The following is a description of a gene set: Any process that decreases the frequency, rate or extent of cell communication. Cell communication is the process that mediates interactions between a cell and its surroundings. Encompasses interactions such as signaling or attachment between one cell and another cell, between a cell and an extracellular matrix, or between a cell and any other aspect of its environment. Mouse Gene Set: GOBP_NEGATIVE_REGULATION_OF_CELL_COMMUNICATION species: Mus musculus, and this is the list of marker genes: Kalrn, Bcl2l10, Foxh1, Cgas, Cul3, Actn3, Oprk1, Slc24a1, Sharpin, Nxn, Pde4c, Icam1, Ddrgk1, Ppif, Dyrk2, Eid2, Cer1, Sorcs2, Tle4, Nherf4, Wdr91, Rgs20, Ddit4l, Leprotl1, Fgf10, Itga3, Ptgs2os (prostaglandin-endoperoxide synthase 2, opposite strand), Sbno1, Nkiras1, Cav3, Epha7, Ffar3, Prex1, Fkbp1a, Traip, Cd300lf, Zdhhc18, Wnt1, Sco1, Ctnna1, Neurod1, Dgkd, Pycr1, Bdnf, Ddias, Tnfaip1, Men1, Edn3, Mgrn1, Tnfrsf4, Trex1, Npy2r, Fam89b, Hmgcr, Tgif1, Htr2a, Cav1, Dkk3, Rgs1, Arc, Dusp1, Endog, Arrdc1 (arrestin domain containing 1), Snai1, Trim67, Nme5, Ar, Padi2, Trabd2b, Ager, Inpp5a, Gstp3, Fgfrl1, Ppp2ca, Dnaja1, Cry1, Mapkap1, Ppt1, Dhx58, Hapstr1, Insig1, Pde8b, Syt4, Grk5, Gjd3, Prkcq, Tnip1, Dusp10, Mark3, Lyplal1, Gper1, Nprl3, Atm, Zfp592, Tle7, Sulf1, Socs5, Stambp, Csnk2a1, Fktn, Aida, Lect2, Rgs2, Nkd2 (NCBI Gene Id 72293), Acod1, Gpr21, Prkar2a, Nprl2, Eif2a, Bcl2l12, Cyp2j6, Lingo1, Kcnj6, Styxl2, Rnf152, Ttll12, Tbk1, Epm2a, Xdh, Tnip2, Sh3bp1, Gnal, Kank2, Pde3a, Snx1, Bmp4, Cd109, Fgf9, Frzb (frizzled-related protein), Arhgap12, Prkar2b, Lmo3, Crh, Tnf, Igbp1, Htr1b, Spi1, Gfral, Hmox1, Sike1, Adora1, Zfp385a, Sfrp5, Rnf31, Bmper (NCBI Gene Id 73230), Cdc34 (cell division cycle 34), Wnt5b, Rnf113a1, Atxn1, Cyrib, Rnf126, Tyro3, Ncor1, Aars1, Glis2, Faim2, Plin5, Lemd2, Igfbp5, Sec14l1, Fbxw8, Spart, Ppia, Opa1, Stau2, Skor1, Hhex, Dusp7, Apln, Il10 (NCBI Gene Id 16153), Ffar4, Mapt, Tmem53, Ezh2, Hgs, Itga1, Tnfrsf23, Rgs19, Ubac2, Kcnc4 (potassium voltage gated channel, Shaw-related subfamily, member 4), Srf, Pea15a, Nr4a2, Tax1bp1, Calr, Ska3, Tmem170b, Dusp2, Adar, Ifi203, Ly6g6e, Snx6, Otud5, Prdm16, Itpr1, Ptger3, Alg13, Gmip, Faiml, Spink1, Emd, Itfg2, Oas1e, Pafah1b1, Dll1, Il7, Ankrd6, Prdm14, Isl1, Nbl1, Xbp1, Stat3, Homer2, Sh2d1a, Ppp6c, Ptpmt1, Tgfb2, Lamp2, Fermt1, Hgf, Fgg, Rb1cc1, Arhgap17, Txndc12, Mmp12, Smpdl3b, Dcn, Peli1, Strip1, Slc2a10, Rps6kb2, Necab2, Lilrb4b, Arhgap29, Herc2, C1ql4, Fbxl2, Mstn, Pten, Bok, Rubcn, Grk3, Mup11, Fzd6, Cx3cr1, Pirb, Trp53, Parp14, Cd300a, Dusp13b, Lats1, Dyrk3, Gja1, Nrarp, Chrna10, Lztr1, Nherf2, Pde10a, Hey2, Pbld2, Olfm4, Dsg3, Pibf1, Edn1, Crebrf, Tcf21, Tgfbr3, Pdpk1, Nos1, Wnk1, Hacd3, Notum, Lefty1, Pawr, Tmc8, Tsc1, Pik3ip1, Sdhaf2, Atf3, Aspn, Megf8, Dmd, Dag1, Trim32, Cyp7b1, Hmgb2, Shisa2, Dusp5, Cd74, Brms1l, Dicer1, Nepn, Faim, Nlrp3, Irs1, Muc1, Tnfaip8l1, Spry1, Pvrig (NCBI Gene Id 102640920), Fignl1, Lgmn, Dab2, Stat1, Cav2, Draxin, Aatf, Rapgef4, Prr5l, Oprl1, Jagn1, Fzd9, Sesn2, Lrp1, Phlda3, Pttg1ip, Avpr1a, Nmi, Ifi206, Kctd10, Dand5, Mad2l2, Dnm1, Twist1, Vegfa, Rasal3, Dkk1, Mad2l1bp (NCBI Gene Id 98050), Tspan15, Ppp1r10, Myoz1, Foxo3, Maz, Gstp2, Parl, Asb15, Tmbim6, Pdcd6, Adamtsl2 (ADAMTS-like 2), Prdx2, H2bc21 (NCBI Gene Id 99855), Cd59a, Cidea, Amfr, Pbk, Il12b, Rbx1, Cd2ap, Rnf149, Wnt16, D1Pas1, Rgs12, Ptgir, Ptgs2, Csnk1a1, Snx25, Insig2, Pmepa1, Ndrg4, Fstl4, Nanog, Gipr, Zfp653, Ezr, Rgs10, Ctnnd1, C1qtnf3, Usp15, Pik3cb, Shisa6, Hif1a, Nlrp12, Fcrl5 (NCBI Gene Id 329693), Stat2, Spry4, Myadm, Mvp, Grem2, Tmem88b (transmembrane protein 88B), Ndufs3, Lrp6, Naip2, Mgll, Mllt3, Ghsr, Peg10, Ppp2r3a, Cd3e, Tns2, Rpgrip1l, Samhd1, Rasip1, Prkar1b, Drd1, Eya4, Ptprv, Per1, Rgs13, Eya3, Vgll4, Tnfsf4, Gdf15, Sall1, Nck2, Nol3, G3bp1, Bcl2l1, Hyal2, Wnt7b, Cxxc4, Kif26a, Ubr5, Cish, Nlrc5, Sag, Ppp1r9a, Dusp22, Hspa5, Entrep1, Ern1, Nlrx1, Smpd3, Pde4d, Pip4k2c, Bcl9l, Sirt2, Abl1, Gprc5a, Stxbp1, Tbx1, Grk2, Nfkbid, Nf1, Fga, Akt2, Grm5, Tjp2, Il1b, Slit2, Chst11 (NCBI Gene Id 68647), Litaf, Ptch1, Ddit4, Serpine1, Gnaz, Vrk3, Naip6, Tnr, Mad1l1, Barx1, Tle1, Bmt2, Trem2, Rrm2b (NCBI Gene Id 382985), Gdf3, Tet1, Camk2b, Kctd6, Itgb1, Atad3a, Tmem131l, Rasa2, Smad6, Pbp2, Raf1, Banf1 (NCBI Gene Id 98145), Dlx2, Tmprss6, Dlk1, Ada (NCBI Gene Id 11486), Erfe, Usp47, Ackr3, Rgs8, Slit3, Ifi214, Ptprd, Pik3ap1, Clec12b, Oas1c, Defb21, Ldlrad4, Sost, Thy1, Fxn, Spred2, Neurl1a, Pip4k2b, Dgkg, Cthrc1, Pak5, Stk3, Cby1, Nkx2-5, Sorl1, Irak3, Adamts12, Ptpn6, Apc2, Kank1, Kctd11, Fbln1, Nup62, Arrdc3, Vps11, Axin2, Igsf1, Rgs17, Socs3, Obscn, Rab7, Ecm1, Ppef2, C1qbp, Sytl4, Nr0b1, Glra1, Egf, Dlc1, Sar1b, Plcl2, Egr1, Sac3d1, Mmp3, Abl2 (NCBI Gene Id 98214), Pfkl, Optn, Map2k3, Sap30, Eif4e2, Arrb1, Mapkbp1, Foxp1, Pde3b, Znrf3, Pip4k2a, Lzts2, Gpatch3, Ghitm, Map4k4, Fem1a, Grina, Tbc1d1, Dkk4, Pfdn5, Sap130, Grem1, Tkfc (NCBI Gene Id 225913), Adgrg3, Rgs7, Ovol2, Bmal1, Cib1, Ier3, Ghrl, Efna1, Htt, Met, Spry2, Phb2, Rasa4, Trim30a, Lats2, Tle6, Ints9, Dusp16, Fam3d, Sox10, Mapkapk5, Ctdspl2, Chuk (NCBI Gene Id 12675), Brd4, Herpud1, Ywhae, Morn3, Nf2, Dkk2, Adra1a, Lrp2, Rgs5, Pycard, Rph3al, Ifi213, Ndrg2, Shank2, Npc1, Irf1, Ube2n, Cnot2, Agtr2, Bax, Crhr2, Ubr1, Dnaja3, Dusp29, Synj2bp, Ifi208, Irf4, Unc5b, Ncl, Bdkrb2, Cdk11b, Tmbim1, Adm, Ptprr (NCBI Gene Id 19279), Them4, Smpdl3a, Adgra2, Sla2, Ror2, Sesn3, Mdm2, Sfrp2, Usp25, Cryba1, Ube2w, Rgs22, Nherf1, Prkcb, Lrrk2, Oas1a, Map3k7, Smurf1, Mrap, Cdk20, Smad5, Tlr6, Prkcd, Ubash3a (NCBI Gene Id 78824), Usp20, Inpp5f, Mcc, Rgs6, Dok2, Tsg101, Sulf2, Aurkb, Tnn, Dhrs3, Inppl1, Itgb1bp1, Slc24a2, Bcl6, Grb14, Cdc34b, Vps18, Npy5r, Gba1, Cep63, Ngfr, Dusp26 (NCBI Gene Id 66959), Ptprf, Nop53, Lrp4, Mapk8ip1, Eya1, Pcbp4, Socs2, Fuz, Mup5, Adnp, Zc3h12a, Hells, Abhd6, Cbfa2t2, Sirt4, Acp4, Magi2, Kctd13, Casp8, Six3, Oas1h, Ltbp1, Fgfr3, Fgf23, Cry2, Grik2, Tmem64, Ptch2, Chrnb2, Rnf115, Cyld, Abcc8, Rnf125 (NCBI Gene Id 67664), Bicc1, Tcim, Htra3, Vwc2, P2rx7, Cblc, Epn2, Tbx18, Apoe (apolipoprotein E), Rgs14, Ift122, Kdm1a (NCBI Gene Id 99982), Mdm4, Pparg, Scyl2, Ubash3b, Tnk1, Npff, Elf1, Rbck1 (NCBI Gene Id 99156), Erbb3, Inpp5d, Bid, Mup3, Sorcs3, Ndufc2, Ruvbl2, Kdm6a, Rasl11b, Plekha1, Vwc2l, Mtnr1b, Dll3, Esr2, Cdk3, Il1rn, Penk, Hey1 (NCBI Gene Id 99610), Cadm1 (NCBI Gene Id 80622), Scai, Mnt, Uri1, Tprg1l, Trim39, Rrn3, Clu, Ryr1, Smarca4, Znrf4, Nkd1, Dnajb9, Heyl, Socs4, Prmt1, Cth, Mndal, Tarbp2, Fgb, Srebf1, Tradd, Chrna7, Npy1r (neuropeptide Y receptor Y1), Spred1, Akt1s1, Lyn, Notch1, Lgr4, Hdac7, Trim59, Midn, Adam17, Wtip, Chrna9, Arhgap45, Mfn2, Ift172, Qars1, Hnf4a, Scg2 (secretogranin II), Rasa3, Lrrc32, Avp, Drd5, Minar1, Axin1, Cnot9 (NCBI Gene Id 98400), Grik3, Nrg1, Birc2, Brca1, Mcl1, Tnfaip6, Pcbp2 (poly(rC) binding protein 2), Myocd, Rack1, Phf14, Tspo, Arg1, S2bpcox16, Rgs16, Dusp8, Cul7, Sirt3, Usp49, Gpd1l, Ptprs, Htr6, Ankrd26, Cnot7, Apcdd1, Chek2, Kcnb1, Gpr155, Stk38, Dlg5, Psen1, Tnfaip3, Egfr, Sh3glb1, Sirt1, Ofd1, Myoc, Cnksr3, Nog, Prkn, Myo5a, Tob1, Nedd4, Pea15b-ps, Tmem88, Arid4a, Rffl, Mapk7, Anxa5, Snai2, Mapk3, Rbpms2, Paqr3, Mtor, Ube3a, Pdx1, Rasal1, Sirpa, Tbx20, Fbxw11, Crim1, Rnf34, Grk4, Sin3a, Arhgap24, Gsdma3, Arhgap44, Siglecg, Clock, Sema6a, Mup4, Prkca, Cit, Ajuba, Nkx2-1, Hdac1, Treml1, Igtp, Ube2d1, Frmd8, Kics2, Asah2, Slc25a5, Nod2, Gas1, Gclm (glutamate-cysteine ligase, modifier subunit), Gsk3a, Erbin, Kcnq1, Bend6, Fcmr, Tgfb3, Kif7, Tank, Ahsg, Mefv, Sox17, Ptpro, Socs1, Creb3, Arhgap22, Ifi207, Sirt7, Enpp1, Aplnr, Mmp9, Gpr108, Tsc2, Mavs, Gps2, Gigyf2, Spsb3, Kctd21, Nphp3 (NCBI Gene Id 74025), Src, Lfng, Il1r2, Mdfi, Rgs18, Lpar1, Irgm1, Il6, Prelid1, Ccar2, Slc35c1, Trim15, Gcg, Ing1, Fnip1, Pias4, Inhbb, Ivns1abp, Tle5, Tacr2, Heg1 (NCBI Gene Id 77446), Mup2, Socs6, Prkacb, Slamf1, Cmya5, Pam16, Sarm1, Cx3cl1, Adra1b, Smpd1, Foxo1, Phb1, Fyn (Fyn proto-oncogene), Plk3, Nfkbil1, Nr1d1, Inha, Gnao1, Ucp2, Zgpat, Zfp451, Pdia6, Ulk3, Cntnap2, Timp2, Irak2, Cbln1, Ffar2, Ptprt, Usp7, Cd22, Zfyve28, Oas1b, Ube2b, Ska1, Drd2, Il6st, Acaa2, Rab11fip5, Mob4, Bag5, Lgals3, Grb2, Nrp1, Ufl1, Nfe2l2, Shank3, Rnf167, Prkaa1, Rgs4, Fbxo7, Cnmd, Strn3, Uaca, Rps6ka1, Cactin (NCBI Gene Id 70312), Inpp5e (inositol polyphosphate-5-phosphatase E), Acvr1c, Oprm1, Glg1, Cd38, Cttn, Dll4, Errfi1, Gria1 (glutamate receptor, ionotropic, AMPA1 (alpha 1)), Pebp1, Azi2, Mul1, Igf1r, Edn2, Ppp2cb, Mir210 (microRNA 210), Pld2 (NCBI Gene Id 18806), Onecut1, Ptpn1, Wwc2, Dynlt1b, Rbbp4, Capn1, Gli1 (GLI-Kruppel family member GLI1), Xiap, Rian, Otud4, Rest, Syvn1, Smim30, Rnf170, Slc24a4, Serpine2, Lmbr1l, Chga, Rgs11, Rcan1, Stub1 (STIP1 homology and U-Box containing protein 1), Bak1, Otud3, Gsk3b, Snx5, Csk, Agt, Il19, Creb3l1, Sap30l, Palm, Pbld1, Dusp4, Trap1 (NCBI Gene Id 68015), Otop1, Siah2, Tbc1d10c (TBC1 domain family, member 10c), Fkbp1b, Sgk3, Itgav, Stradb, Ptprc, Suds3, Chrdl2, Map2k5, Strn4, Prkaca, Rapgef1, Rb1, Ythdf2, Irgm2, Tulp3, Tpt1, Aplp1, Rab11fip1, Gstp1, Ppm1a, Drd3, Bmp2, Zfp366, Tcf7l2, Ptk2b (NCBI Gene Id 211703), Uchl1, Slc27a4, Suz12, Nphp4, Sstr4, Agap2, Blvrb, Zbtb7a, Gli3, Atf6b, Lrrc14, Asb3, Hif1an, Bfar, Prkcz, Dgki, Sostdc1, Rela, Parp1, Ctnnbip1, Tsku, Hrg, Bmi1, Wnt5a, Sfrp1, Prkar1a, Gpr37l1, Ripk1, Dlx1, Zfp536, Ucma, Arhgap42, Rfng, Ythdf3, Il11, Crtc3, Cgnl1, Slmap, Rita1, Prdm15, Phip, Tmsb4x, Adra2a, Twsg1, Veph1, Ogt (O-linked N-acetylglucosamine (GlcNAc) transferase (UDP-N-acetylglucosamine:polypeptide-N-acetylglucosaminyl transferase)), Rps6kb1, Rgs7bp, Phlpp1, Ubr2, Tle2, Bmp5, Dok1, Bche, Ccdc22, H2-M3, Rbbp7, Cldn18, Fhl2, Atp2b4, Atf4, Smad7, Jade1, Nfkbia, Hdac2, Dgkz, Yap1, Wnt11, Ptpru, Brms1, Rptor, Dnm2, Triap1, Grid2, Sox13, Stmn3, Sh3rf2, Marchf7 (membrane associated ring-CH-type finger 7), Chac1 (NCBI Gene Id 69065), Vhl, Ticam2, Il36rn, Igf1, Castor2, Herc4 (hect domain and RLD 4), Pik3r2, Mesp1, Appl1, Vcp, Cabp1, Lbh, Oas1d, Pink1, Fstl3, Shisa3, Acvr1, Mfhas1 (NCBI Gene Id 71940), Nanos3 (NCBI Gene Id 244551), Flcn, Isg15, Tspan6, Dlg1, Psca, Igfbp3, Pdcd4, Sinhcaf, Birc7, Psmd10, Eno1, Ikbkg, Naip1, Armc10, Shh, Eif2ak3, Dusp3, Rgs3, Stxbp5l, Lilrb4a, Deptor, Rora, Klhl31 (NCBI Gene Id 320711), Abca7, Chd8, Ptpn2, Arid4b, Homer3, Rhoa, Tlr4, Hipk3, Fgf2, Marveld3, Dkkl1, Tlr9, Tmem127, Slc39a8, Sall3, Slc35f6, Mrtfa, Crhbp (NCBI Gene Id 12919), Gnai2, Ski, Leprot, Apc, Atxn7, Hhip, Trim33, Prnp, Itga6, Sh2b3, Ywhag, Cxcl12 (NCBI Gene Id 20315, C-X-C motif chemokine ligand 12), Lonp1, Atxn3, Rgs9, Vps25, Rtkn2, Lpxn, Hyou1, Cnot1, Becn2, Nlk, Hjv, Dusp19, Fbn1, Chrdl1 (chordin-like 1), Riok3, Alpk2, Mpv17l, Ccdc125, Fst, Egln1, Rps6ka6, Pkia, Snca, Pim3, Csf2, Ubqln2, Pcgf2, Rbms3, Arrb2, Slc6a4 (solute carrier family 6 (neurotransmitter transporter, serotonin), member 4), Dcst1, Klf7, Apod, Ctnnb1, Fmr1, Inpp5k, Plek, Strap, Gclc, Nmb (NCBI Gene Id 68039), Eif3a, Arhgap35, Pick1, Rnf213, Hic1, Mir143, Map2k1, Gbp7, Emilin1, Cd160, Slc6a1, Slc25a4, Ppp3ca, Gnai3, Tmem161a, Epha4, Nono, Sfrp4, Ndufa13, Trim31, Lax1, Gata3, Eny2, Btnl2, Ucn2, Kcnk9, Lep, Sh3rf1, Huwe1, Iqsec2, Ccdc88c, Btn2a2, Adcy8, Psme3, Hspa1b, Sesn1, Ywhaz (NCBI Gene Id 68643), Mup1 (major urinary protein 1), Rfx4, Prkaa2, Mpig6b, Tnip3, Cflar, Tbc1d7, Dab2ip, Ift80 (intraflagellar transport 80), Spred3, Traf2, Bcl2, Chp1, Trp63, Itch, Wwox, Cilp, Tax1bp3, Lemd3, Mtnr1a, Mir423, Wwc1, Epo, Wfikkn2, Sod2, Gsc, Il17rd, Ppp2r1a, Hcrt, Gata2, Ccn3, Mtmr4, Dab1 (NCBI Gene Id 545665), Meis3, Ywhab, Ubqln1, Ifi203-ps (interferon activated gene 203, pseudogene), Tpbg, Depdc5, Nfatc4, Adrb2, Mmrn2, Mettl3, Wfikkn1, Phpt1, Nploc4, Cadm4, Sigirr, Mapk14, Cd44, Ybx3, Amer1, Limd1, Cripto, Nkx3-1, Park7 (NCBI Gene Id 57320), Ripor1, Prex2, Psmd9, Tert, Apela, Hspb1, Aurka, Ephb2, Arf1, Gpx1, Kremen1, Dusp6, Fbn2, Ptprj, Pak1ip1, Tnfrsf1a, Myoz2, Mecom, Rnf113a2, Tgfbr1, Cdh3, Chrd, Cdkn2a, Ppara, Gpr161, Rab11fip3, Prkdc, Cblb, Pin1, Cyp26b1, Castor1, Ddx3x, Ufd1, Ifi209, Cartpt, Cdkn2d, Stmn1 (NCBI Gene Id 16765), Pmch, Ceacam1, Gramd4, Pde2a, Skil (NCBI Gene Id 71615), Ncor2, Stk11, Amer2, Laptm5, Otud7b, Gprasp1, Wwtr1, Naip5, Gabbr1, App, Notch4, Ash1l, Phactr4, Bcl3, Prap1, Nlrp6, Commd1 (COMM domain containing 1), Nkiras2, Rabgef1, E130311K13Rik, Cpne1, Gpc3, Selenos, Snx13, Grm2, Gata1, Gpr35, Fbp1, Sox2, Cd46, Nrros, Plaur, Eno1b, Skor2, Gdpd5, Vasn, Prickle1, Traf3ip1, Cavin3, Bmp7, Cptp, Prrt1, Lox, Ptpn22, Ltf, Tpbgl, Tle3, Foxm1, Vsnl1, Socs7, Ptpre, Kptn, Sox9, Ripor2, Grb10, Bmf, Aim2, 2210016L21Rik, Zmynd11, Usp10 (ubiquitin specific peptidase 10), Dlk2, Vdac2, Psen2, Mrap2, Asxl1, Adipoq, Ccnc, Akt1, Oas3 (2'-5' oligoadenylate synthetase 3), Tfap2a, Grb7, Aars2, Slc25a31, Bank1, Btrc, Hadh, Peli3 (pellino 3), Wnk2, Ccdc3, Runx2, Ndufaf2, Tnfrsf22, Itprip, Stap1, Rab7b, Lmna, Pias2, Cdk5rap3, Hmga2, Apoa1, Bambi, Kcnj11 (potassium inwardly rectifying channel, subfamily J, member 11), Snip1, Ranbp9 (RAN binding protein 9), Gdnf, Tnfrsf11b, Bpifb1, Oas1f, Oas1g, Atad1, Madd, Trim11, Smad4, Dact2, Usp18, Il4, Mir675, Ccl5, Rgs9bp, Il12a, Pcdh17, Ikbkb, Pin1rt1, Invs, Mmrn1, Szt2, Ppm1b, Ifi35, Dact3, Esr1, Noc2l, Smurf2, Mir154, Ing2, Gli2, Hspa8, Gas6, Hipk2, Syngap1, Htra1, Cdc42se1 (NCBI Gene Id 99930), Sar1a, Map3k20, Ncoa5, Wnt4, Arhgap25, Trib1, Pkhd1, Nck1, Fzd1, Dact1, Mif, Sufu, Wif1, Kcnq4, Trim72, Ell3, Nr1h4, Sh3bp4, Akt3, Mkrn2, Abhd17a, Stk4, Arr3, Hdac3, Mmp14, Pid1, Gpc1, Cbl, Onecut2, Mosmo, Ptpn11, Uts2, G2e3, Ucn, Npvf, Birc6, Atad5, Egfl7, F2rl1, Plk2, Yju2, Klk14, Adipor1, Klf4, Nucb2, Ggnbp2, Pla2g6, Ace2, Vps13a, Pde11a, Nlrc3, Tmed2, Palm3, Tmem14a, Mdk, Higd1a, Cnr2, Itpripl1, Dyrk1a, Brap (NCBI Gene Id 72399), Robo1 (NCBI Gene Id 436378), Chmp6, Pp2d1, Ddit3, Grk6, Csnk1e, Bicd1, Nppa, Dusp9, Gata4, Wfs1, Grid2ip (NCBI Gene Id 170935), Grik1, Thbs1, Rhoh, Trim60, Sox30, Bcl2l2, Nodal, Pde1c, Sqstm1, Eya2, Drd4, Col2a1, Taok3, Cdh1, Zdhhc12, Mtm1, Gstp-ps, Osm, Cdh2, Rassf2, Gnai1, Git1, Rnf43, Tns3, Mapk8ip2, Lif, Spaar, Cnot3